Given this list of marker genes CLEC6A, HLA-A, PGLYRP1, PGLYRP3, PGLYRP2, NOD1, CLEC7A, SSC5D, NLRC4, NAIP, TLR2, NOD2, TLR4, PGLYRP4, TLR6, HLA-B, CD1D, TLR1 (NCBI Gene Id 7887), HLA-DRB1 (NCBI Gene Id 730415), here is a description of the gene set: The series of events in which a stimulus from another organism is received and converted into a molecular signal. Human Gene Set: GOBP_DETECTION_OF_OTHER_ORGANISM species: Homo sapiens